The following is a description of a gene set: studied in species Homo sapiens The process in which the renin-angiotensin system controls the rate of fluid intake and output into the blood. Human Gene Set: GOBP_REGULATION_OF_BLOOD_VOLUME_BY_RENIN_ANGIOTENSIN, and this is the list of marker genes: AGTR2, ACE2, CYBA (cytochrome b-245 alpha chain), RPS6KA2, REN, TACR1, AGTR1, AGT, ACE